Given this list of marker genes Vsir, Ahr, Nckap1l, Bcl6, Il7r, Gfer, Zp3r, Parp3, BC037156, Ceacam1, Tbx21, Cd46, Serpinb9, Sh2d1b1, Serpinb9f, Cd80, Serpinb9g, Ufl1, Inpp5d, Tgfb1, Lilrb4b, Nod2, C4bp, Lilrb4a, Clec4g, Crk, Cr1l, Ptpn6 (protein tyrosine phosphatase, non-receptor type 6), Lgals9, Serpinb9c, Cr2, Tap1, Nectin2, Pdcd1, Cd96, Spn, Smad7, Sh2d1b2, H2-T23, Mill1, Klrb1b, Serpinb9h, Il4i1, Muc4, Il20rb, Serpinb9d, Ndfip1, Ptprc, Slamf1, Klre1, Serpinb9b, Nectin4, Igf2, Arg1, Serpinb9e, Ppp3cb, Fcgr2b, Ifnb1, Havcr2, Hfe, Clec12b, Clec2d, Tap2, Susd4, Foxj1, Klrd1, Grb2, H2-M3, Foxp3, Cd274, Arrb2, Dusp22, here is a description of the gene set: Mouse Gene Set: GOBP_NEGATIVE_REGULATION_OF_LYMPHOCYTE_MEDIATED_IMMUNITY species: Mus musculus Any process that stops, prevents, or reduces the frequency, rate, or extent of lymphocyte mediated immunity.